Given this list of marker genes PCBP1, AGBL5, ENPP3, PCBP1-AS1, COX20, KCTD5, DGKQ, PRRC2A, ZNF839, MCRIP2, DPY19L4 (dpy-19 like 4), MED23, KMT5B, IPO4, RALY, MZT2A (mitotic spindle organizing protein 2A), AGBL5-AS1, METTL26, IDUA, DHRS2, TMX4, SMPD4BP, NUDCD3, H2BC5, MRPS31P5, TMX4-AS1, CHMP6, MAZ, ARHGDIA, MARK4, CPPED1, CALM2, SNAI1, CCDC97, GEMIN7, TRIM47, ILF2, MLEC, NOP58, here is a description of the gene set: Genes containing one or more binding sites for (RUVBL2) in their promoter regions (TSS -1000,+100 bp) as identified by GTRD version 20.06 ChIP-seq harmonization. from publication Yevshin I, Sharipov R, Kolmykov S, Kondrakhin Y, Kolpakov F (PMID 30445619) Human Gene Set: RUVBL2_TARGET_GENES species: Homo sapiens